Given this list of marker genes Ly6g6e, Apela, Arr3, Grm5, Dnm2, Ptger3, Adm, Camk2b, Grk5, Necab2, Aplnr, Arrb1, App, Grk6, Pld2, Arrb2, Apln, Ubqln2, Dnm1, Grk2, Grk4, Gipr, Drd2, Drd3, Entrep1, Sag, Grk3, here is a description of the gene set: The negative regulation of a signal transduction pathway in response to a stimulus upon prolonged exposure to that stimulus. studied in species Mus musculus Mouse Gene Set: GOBP_NEGATIVE_ADAPTATION_OF_SIGNALING_PATHWAY